Given this list of marker genes ARID5B, SLC25A5, SMARCA5, PADI2, BSPRY (NCBI Gene Id 54836), TNFSF11, TRIM2, SOX17, DTX1, RFX2 (NCBI Gene Id 5990), PLA2G10, MYNN, RARG, RNF138, MSC, NEFH, KDM3A, KLF4, NRP2, NUP35, CTH, NME7, HK2, ILDR1, KLF5, MYBL2, LRAT, MAT2A, BCAT2, RNF125, MCF2, EFHC2, MIR370, MTF2, BCLAF1, MIR433, RIF1, SPOCK2, SMAD7, PMM1, SHMT1, ADAM23, TLE4, HNRNPU, ICAM1, MIR224, XRCC5, FZD4, MIR342, NCL, PTP4A3, MIR455, SBNO2, GLDC, EIF4A2, EPS8, MRPL15 (NCBI Gene Id 65001), SRSF7, PML, WDR35, SYNGR1, KDM5B, VEGFC, GCLM, SOCS3, HELLS, FOSL2, INA, NFYB, EXT1, CACNB4, PFKP, EEF1E1 (eukaryotic translation elongation factor 1 epsilon 1), CACYBP, PAX6, JARID2 (jumonji and AT-rich interaction domain containing 2), EED, SPRY2 (sprouty RTK signaling antagonist 2), RPS16, TFRC, MYB, MIR493, SRM, GNPNAT1, SNX10, XBP1, LAPTM5, NR5A2, PRDM5, SOX1, PCOLCE2, ABCG4, RNMT, CREB1, ABCD4 (NCBI Gene Id 5826), TRIM25, GFPT2, TEX14, PHC1, PIGA, FGF4, SSTR1, PARP16, PDCD10, SPRY4, MRAS, MIR324, B3GNT2, POLR1F, SRSF3, SIRT1, UBXN2A, here is a description of the gene set: species: Homo sapiens Any process that results in a change in state or activity of a cell or an organism (in terms of movement, secretion, enzyme production, gene expression, etc.) as a result of a leukemia inhibitory factor stimulus. Human Gene Set: GOBP_RESPONSE_TO_LEUKEMIA_INHIBITORY_FACTOR